Given this list of marker genes Prkn, Pink1, Acsl1, Mul1, Vdac3, Fundc2b, Psen1, Nucb2, Nav3, Mavs, Atad1, Tigar, Cstad, Cnp, Nlrx1, Dhcr7, Clmn, Plec, Rnf185, Epha4, Moap1, Lrpprc, Ppp2r2b, Rhot2, Bax, Armcx2, Pebp1, Slc22a3, Itpr3, Bak1, Ufl1 (UFM1 specific ligase 1), Letmd1, Cox14, Mgst1, Mff, Mtfr1l, Msto1 (misato 1, mitochondrial distribution and morphology regulator), Cnr1, Gpat2, Acsl5, Bok, Dmd, Fam210b, Acacb, Mcl1, Cisd2, Miga2, Syne4, Mtch1, Fbxl4, Bcl2a1a, Fate1 (fetal and adult testis expressed 1), Slc8a3, Hadhb, Armcx6, Bri3bp, Armc10, Usp30, Syne2, Aifm1, Vps13a, Ppp1r15a, Mief2, Rps6kb1, Miga1, Ptrh2 (peptidyl-tRNA hydrolase 2), Kash5 (KASH domain containing 5), Snca, Trabd, Mfn1, Slc27a1, Sh3glb1, Tspo, Asl (NCBI Gene Id 76802), Wasf1, Tomm5, Bcl2a1d, Cpt1a, Nutf2-ps1, Dao, Bid, Tomm70a, Exd2, Itprip (inositol 1,4,5-triphosphate receptor interacting protein), Mgarp, Tspo2, Acsl3, Agpat4, Bcl2a1b, Nme1, S2bpcox16, Vdac2, Atf2, Marchf5, Grk2, Capn10, Muc20, Nutf2, Traf3ip3, Acsl4, Samm50, Mfn2, Dele1, Slc25a46, Mgst3, Lpin1, Tmem53, Smpd4, Ptgs2, Sox10, Vat1, Gja1, Rab32, Gk, Serac1, Slc11a2, Vps13c (NCBI Gene Id 97581), Ugt2b1, Tomm6, Trappc2b, Ugt2b38, Lrrk2, Slc44a1, Pld6 (NCBI Gene Id 194908), Acsl6, Emd, Cpt1b, Pgrmc1, Tomm22, Ppp1cc, Bnip3l-ps, 4930550C14Rik, Ugt2b5, Sfxn2, Gk2, Rhot1, Tmem109, Tomm20, Tomm7, Bcl2l2, Spata18, Nos1, Mtx1, Bad, Slc44a2, Fundc2, Myoc, Qtrt2, Ass1, Foxo3, Nme3, Armcx1, Tomm40l, Mtarc2, Armc12, Mtx3, Smim26, Pigbos1, Spire1, Phb2 (NCBI Gene Id 12034), Hax1, Retsat, Slc25a47, Ubc, Cyb5b, Cptp, Aifm2, Prnp, Nelfb, Ntrk3, Ugt2b37, Eno1b, Neu4, Armcx3, Phb1, Mtx2, Bcl2l10, Syne3, Bcl2a1c, Ubb, Cyb5r3, Bcl2, Trim14 (NCBI Gene Id 74735), Spart, Vdac1, Maob, Gimap3, Pde2a, Rtn4ip1, Stmp1, Bnip1, Agtr1a, Synj2bp, Pi4kb (NCBI Gene Id 99948), Syne1, Mapkap1, Coasy, Sting1, Ghrhr, Fis1, Nipsnap2, Kmo, Fundc1, Arg1, Gpam, Tomm34, Dmpk, Mtarc1, Snn, Pptc7, Hk1, Misfa, Sigmar1, Pla2g2a, Spata19, Tomm40, Slc25a4, Armc1, Pgam5, Hk2, Akap1, Ltc4s, Bnip3l, Mtch2, Bnip3 (NCBI Gene Id 12176), Rab11fip5, Znfx1, Mt3, Sarm1, Dnm1l, Tomm20l, Becn1, Rmdn3, Abcb6, Mtor, Mlxip, Rsad2, Tafazzin, Cisd1, Eno1, Myo19, Qtrt1, Maoa (NCBI Gene Id 68831), Bcl2l1, Dnajc11, Opa1, Mief1, Gdap1, Smcp, here is a description of the gene set: Mouse Gene Set: GOCC_OUTER_MEMBRANE species: Mus musculus The external membrane of Gram-negative bacteria or certain organelles such as mitochondria and chloroplasts; freely permeable to most ions and metabolites.